Given this list of marker genes CD1D, CD1B, CD1E, CD1C, CD1A, here is a description of the gene set: The process in which an antigen-presenting cell expresses lipid antigen of endogenous origin in association with an MHC class Ib protein complex on its cell surface. Class Ib here refers to non-classical class I molecules, such as those of the CD1 family. Human Gene Set: GOBP_ANTIGEN_PROCESSING_AND_PRESENTATION_ENDOGENOUS_LIPID_ANTIGEN_VIA_MHC_CLASS_IB studied in species Homo sapiens